The following is a description of a gene set: studied in species Homo sapiens Human Gene Set: HP_DOUBLE_AORTIC_ARCH Double aortic arch A conenital abnormality of the aortic arch in which the two embryonic aortc arches form a vascular ring that surrounds the trachea or esophagus and then join to form the descending aorta. Double aortic arch can cause symptoms because of compression of the esophagus (dysphagia, cyanosis while eating) or trachea (stridor)., and this is the list of marker genes: TELO2, DGCR8, FLT4, CIROP, TBX1, DGCR6, DGCR2, GBA1, ESS2